Given this list of marker genes Smim22, Mospd2, Cds2, Rnf213, Sqle (NCBI Gene Id 20775), Pisd, Bscl2, Pla2g4c, Zfyve1, Fitm1, Ldaf1 (NCBI Gene Id 78502), Negr1, Cds1, Aup1, Fitm2, here is a description of the gene set: Mouse Gene Set: GOBP_LIPID_DROPLET_FORMATION species: Mus musculus A process that results in the assembly, arrangement of constituent parts of a lipid droplet.